The following is a description of a gene set: studied in species Homo sapiens Human Gene Set: WP_CHROMOSOMAL_AND_MICROSATELLITE_INSTABILITY_IN_COLORECTAL_CANCER Chromosomal and microsatellite instability in colorectal cancer, and this is the list of marker genes: MAPK10, ARAF, TCF7L1, RHOA, MSH2, SMAD2, APPL1 (NCBI Gene Id 26060), BIRC5, CYCS, TBK1, CCND1, AKT1, GSK3B, RAC3, DDB2, LEF1, BCL2L11, POLK, AKT3, MLH1, CTNNB1, MYC, CSNK1A1L, BCL2, PMAIP1, AXIN2, TP53, CASP3, MSH6, TGFB3 (NCBI Gene Id 7043), BAX, MAPK3, BBC3, TGFBR2, RALA, CASP9, DCC, GADD45A, APC2, RAC2, NTN1, MAPK9, MAP2K1, CDKN1A (cyclin dependent kinase inhibitor 1A, NCBI Gene Id 1026), TCF7L2, TGFB1, KRAS, AXIN1, JUN, TGFBR1 (transforming growth factor beta receptor 1), RAF1, MSH3, EXOC2, REL, FOS, TCF7, SMAD4, SMAD3, MAPK8, APC, RALB, MAPK1, BRAF, GADD45G, BAD (BCL2 associated agonist of cell death), CSNK1A1, PTGS2, AKT2, GADD45B, RAC1, BAK1, RALGDS, TGFB2